The following is a description of a gene set: Genes up-regulated in peripheral blood mononuclear cell 7d vs 0d in adults (18-45) after exposure to YF-17D vaccine, time point 7D studied in species Homo sapiens Human Gene Set: QUEREC_PBMC_YF_17D_VACCINE_AGE_18_45YO_7DY_UP A major challenge in vaccinology is to prospectively determine vaccine efficacy. Here we have used a systems biology approach to identify early gene 'signatures' that predicted immune responses in humans vaccinated with yellow fever vaccine YF-17D. Vaccination induced genes that regulate virus innate sensing and type I interferon production. Computational analyses identified a gene signature, including complement protein C1qB and eukaryotic translation initiation factor 2 alpha kinase 4-an orchestrator of the integrated stress response-that correlated with and predicted YF-17D CD8(+) T cell responses with up to 90% accuracy in an independent, blinded trial. A distinct signature, including B cell growth factor TNFRS17, predicted the neutralizing antibody response with up to 100% accuracy. These data highlight the utility of systems biology approaches in predicting vaccine efficacy. from publication Querec TD, Akondy RS, Lee EK, Cao W, Nakaya HI, Teuwen D, Pirani A, Gernert K, Deng J, Marzolf B, Kennedy K, Wu H, Bennouna S, Oluoch H, Miller J, Vencio RZ, Mulligan M, Aderem A, Ahmed R, Pulendran B (PMID 19029902), and this is the list of marker genes: PARP12, STAT1, TRIM22, ISG15, RASA2, IL10, IFIT1, SAMD9, IFI27, OAS1, IFIT2, DDX60L, TMEM255A, IRF7, IFIT3, XAF1, PNPT1, MYOF, SERPING1, HERC5, LAMP3, MX1, DDX60 (NCBI Gene Id 55601), IFI44L, C3AR1, OAS2, IFIH1, TLR7, TRIM5, RGL1, OASL, PLSCR1, LGALS3BP, RSAD2, CXCL10, IFI6, MX2, DHX58, CD38, OAS3, PARP9, NEXN, IFI44, RIGI, SAMD9L, EIF2AK2